The following is a description of a gene set: Genes negatively differentially expressed in cell type: cDC2 (conventional dendritic cell type 2) upon treatment with cytokine: TL1A in mouse lymph nodes in vivo. from publication Cui A, Huang T, Li S, Ma A, Pérez JL, Sander C, Keskin DB, Wu CJ, Fraenkel E, Hacohen N (PMID 38057668) Mouse Gene Set: CUI_CDC2_TL1A_RESPONSE_DN species: Mus musculus Cytokines mediate cell-cell communication in the immune system and represent important therapeutic targets. A myriad of studies have highlighted their central role in immune function, yet we lack a global view of the cellular responses of each immune cell type to each cytokine. To address this gap, the authors created the Immune Dictionary, a compendium of single-cell transcriptomic profiles of more than 17 immune cell types in response to each of 86 cytokines (>1,400 cytokine-cell type combinations) in mouse lymph nodes in vivo. A cytokine-centric view of the dictionary revealed that most cytokines induce highly cell-type-specific responses. For example, the inflammatory cytokine interleukin-1β induces distinct gene programmes in almost every cell type. A cell-type-centric view of the dictionary identified more than 66 cytokine-driven cellular polarization states across immune cell types, including previously uncharacterized states such as an interleukin-18-induced polyfunctional natural killer cell state., and this is the list of marker genes: Abhd12, Ubb, Crebrf, Cd47, Klf2, Ptprc, Clk1, Junb, H1f2, Cd81, Neat1, Il1b, Jup, Zfp36l2, Mxd4, Tsc22d3, Ptgs2 (prostaglandin-endoperoxide synthase 2), Slc66a2, Cyp27a1, Ccrl2 (C-C motif chemokine receptor-like 2, NCBI Gene Id 73654), Fuca1 (NCBI Gene Id 78549), Ffar4, Slc43a2, Hbp1, Nr4a1, Cox7a2l, Smpdl3a, Klhl24, Pid1, Hspa1a, Tnfaip8l2, Plin2, Hexb, Lrrc25, Txnip, Ypel5, Gm2a, Eef2, Ctnna1, Nfkbiz, Rgs2, Ramp1, Dusp1, Fos, Hexa, Il16, Ankrd44, Znrf2, Spn, Tnfsf9, Klf4, Bri3, Aph1c, Creg1, Btg2, Ier2, Ppp1r15a, Fth1, Foxp1, Zeb2, Pou2f2, Fosb, Wdr91, Marveld1, Ccl9, Add3, Arl4c, Bnip3l, Ctsc, Pmaip1, Zfp36, Kmt2c, Cdk14, BC028528, Pdcd4, Rmnd5a, Ncf2, Atf3, Gdi2, Ctsh, Tent5a, Mapk3, Kctd12, Egr1, Pdlim2, Nfkbid, Cytip, Fam107b, Itm2b, Celf2, Slc15a4, Arhgap9, Ccnl1 (cyclin L1)